Given this list of marker genes Ncapd2, Smc4, Ncaph, Ncapd3, Smc2, Ncaph2 (non-SMC condensin II complex, subunit H2), here is a description of the gene set: studied in species Mus musculus Mouse Gene Set: GOBP_MEIOTIC_CHROMOSOME_CONDENSATION Compaction of chromatin structure prior to meiosis in eukaryotic cells.